Given this list of marker genes ME1, PCK2, MDH2, GPD2, ALDOB (NCBI Gene Id 229), LDHC, GPI, ME3, PGAM2, ENO3, ENO2, BID, ALDOC, PGK1, TPI1, ALDOA, ENO1, PCK1, GPD1, ME2, LDHB, LDHA, FBP2, PFKM, PC, MDH1, GAPDHS, GPT, FBP1, GK, CD4, here is a description of the gene set: DNA microarrays can be used to identify gene expression changes characteristic of human disease. This is challenging, however, when relevant differences are subtle at the level of individual genes. We introduce an analytical strategy, Gene Set Enrichment Analysis, designed to detect modest but coordinate changes in the expression of groups of functionally related genes. Using this approach, we identify a set of genes involved in oxidative phosphorylation whose expression is coordinately decreased in human diabetic muscle. Expression of these genes is high at sites of insulin-mediated glucose disposal, activated by PGC-1alpha and correlated with total-body aerobic capacity. Our results associate this gene set with clinically important variation in human metabolism and illustrate the value of pathway relationships in the analysis of genomic profiling experiments. Human Gene Set: MOOTHA_GLUCONEOGENESIS Genes involved in gluconeogenesis; based on literature and sequence annotation resources and converted to Affymetrix HG-U133A probe sets. from publication Mootha VK, Lindgren CM, Eriksson KF, Subramanian A, Sihag S, Lehar J, Puigserver P, Carlsson E, Ridderstråle M, Laurila E, Houstis N, Daly MJ, Patterson N, Mesirov JP, Golub TR, Tamayo P, Spiegelman B, Lander ES, Hirschhorn JN, Altshuler D, Groop LC (PMID 12808457) species: Homo sapiens